The following is a description of a gene set: Human Gene Set: REACTOME_LTC4_CYSLTR_MEDIATED_IL4_PRODUCTION studied in species Homo sapiens LTC4-CYSLTR mediated IL4 production, and this is the list of marker genes: DPEP1, DPEP2, GGT5, GGT1, CYSLTR1, CYSLTR2